Given this list of marker genes XKR6, FBLL1, SMIM18, GRID2, ANKRD44, MMP17 (NCBI Gene Id 51403), BRINP2, PPP3CB, RIPOR2, NFATC2, CACNG8, ST8SIA3, POU2F2, MAP2, C1QL4, TBC1D3, MSANTD3-TMEFF1, LHFPL4, NPY1R, FRMD4A, MEIS2, GPR155, CASZ1, RALGDS, CACNG4, INHBA-AS1, TRIM67, CREG2, PLXNA2, GATA3 (GATA binding protein 3), ZNF568, GSE1, SULT4A1, SEMA3C, SRRM4, C22orf42, ROBO1, CSMD2, KCNC1, CBLN4 (NCBI Gene Id 140689), TTLL7 (NCBI Gene Id 79739), NRN1 (NCBI Gene Id 51299), XIST, OGDHL, PCGF3, PALB2, SMPD3, RIMBP2, PPARGC1B, MAP7D2, KCNC2, SAMD5, PCDH17, NPAS4, FRMD4B, SPAST, PIGX, NALF1-IT1, VHL, FAM171B, TBC1D24, MFSD6, DACT1, CSAD, SNCA, OPRM1, PDZD7, TRIM46, RETREG1, CACNA1C, CNTNAP2, ZFHX3, GLS, CCDC39, PKIA, KIF21B, NELL1, RAB3B, UNC79, ERC1, MTSS1, ATP8A2, UBE2QL1, BAALC, RNF175, CDH4, CHL1, PSD2, RAB6B, SYT4, HS3ST1, GABRG2, CDKN2D, UBN2, CHN1, ERC2, MAP1LC3A, NALCN, GPR12, TFAP2B, CCDC144A, HCN3, AK5 (adenylate kinase 5), STXBP5, PISD, ACSL6, CFAP90, NEGR1, ELFN2, VOPP1, NUAK1, TULP4, SYBU, SORCS1, GAD2, GPM6A, AKAP1, EPHB1, ELAVL4, SNX31, SYT1 (NCBI Gene Id 6857), TMEM121B, PEG3, PFKP, OCRL, FNDC5, GPSM1, CDKL2, LRRC8C, NRXN1, KCTD8, NKAIN2, SLC4A1, GRIA1, TMEM185B, TMEM132B, SLC38A1 (NCBI Gene Id 81539), FAM131B, LRRC3B, TAC1, ATP1A3, TSPAN7, SCN3B, SNORD12, MCF2L, ASIC2, THSD7B, ATP9A, ANKRD36B, SCN7A, GOLGA8B, BCL11B, TESMIN, GNAO1, CACNG2, EPB41L1, TMEM127, DOP1A, CSMD3, NALF1, GABRA1, GRIA2, ADGRB1, SYT7, ELOVL4, CDKL5, PAK5, SCAI, MMP24, FGF14, KIFC2, MAP6, SCG2, CELF3, ATP2B2, DGKE, SPINT2, NDRG4, MAP1B, CACNA1E, MUC19, TMEM178A, CAMK2B, RAP2B, FRY, SLITRK1, SYP, DSC3, EEA1, ARPP21, INA, PLXNA4, ASXL3, ZNF264, CNTRL, PTPRT, DLG2, GABRG1, BRINP1, STAR, PCDHA7, EEF1A2, FLJ16779, CHST1, SDC3, ACSL4, SLC24A3, RUFY3, RUNX1T1, COMTD1, DOK4, SPRED3, ANK1, ANKRD13D, NLN, VSTM2A, MYCBP2, SLC37A1, KIF3B, C12orf76 (NCBI Gene Id 400073), DPP6, CCDC85A, APLP1, FAR2P2 (fatty acyl-CoA reductase 2 pseudogene 2), FRMD3, MYT1L, C11orf87, LRFN5, TBC1D32, ANKRD12, BRSK1, REV3L, UBE2J2, MAPRE3, TLN2, DICER1, REEP2, DCLK1, NDST3, PRRT2, LSAMP, LPIN1, KCNMA1, FNBP1, TMEFF2, TRHDE, PNCK, SPOCK1, ARK2C, LONRF2, SYNPR, CPEB3, NLGN1, LRRTM3, GRM7, NPAS3, KIRREL1, CMIP, EML5, SNAP91, JAG2, SSBP3, OPCML (NCBI Gene Id 4978), NRXN3, HPCAL4, PCDH19, TAL1, SCN1A, CHD5, CRMP1, PITX2, SLC32A1, PDE4D, TMEM35A, CD2, BNC2, TIGD3, ZFHX2, PNMA8B, MTCL3, DPYSL3, EID2B, CDK5R1, SNX1, SLC8A2, PRLR, NPTXR, DSCAM, RASGEF1B (RasGEF domain family member 1B), CNGB1, UNC13A, DNAJC3, MAPRE2, UBE2K, DOCK3 (dedicator of cytokinesis 3), DOCK4, SLC12A5, IKZF4, FGF9, PCDH9, SCAPER, SLCO3A1, GRIK2, TMEM129, ANK2, PKNOX1, SRRM3, CHRNA7, ENSG00000230725, ATP1B1, CCDC184, FAM182B, NRG2, SORCS3 (sortilin related VPS10 domain containing receptor 3), PXK (NCBI Gene Id 54899), AKAP7, ERAP2, GRIN3A, SRCIN1, TUBB2B, SYT13, ATP2B1, TRIM36, MAB21L1, ST3GAL2, RAB11FIP4, ZNF292, CDH8, DMTN, ASNS, GRM4, OPN5 (opsin 5), DYNC1I1, RALYL, BRINP3, SLC5A7, FMN2, PLEKHA6 (pleckstrin homology domain containing A6), SNORD116-29, XPR1, TSHZ2 (teashirt zinc finger homeobox 2), RNF125, SCN9A, KIAA1549L, NAP1L2, SEMA6D, CACNA1G, URB1, RALGPS1, MARK1, BCO2, EPHA5, TUBB3, RASA4, ZFHX4, SH3GL3, PHACTR3, WDFY4 (WDFY family member 4), GABRB3, NEIL1, ANO8, NRXN2, NSG1, PCLO, RTN1, ADAM23, KIRREL3, TGFB2-OT1, NAT1, CNTN4 (contactin 4), PRKAR2B, VGF, CMTM4, YPEL3, CCSER1, ELAVL2, EDIL3, SCN2A, BLTP3B, PAQR8, UBASH3B (ubiquitin associated and SH3 domain containing B), PGM2L1, MIR124-2HG, UCHL1, ARID4A, CACNA1A, RUNDC3B, GPRASP1, PLEKHA1, GRM8, ACVR1B, RAP1GAP2, LGI2, NCAM1, NBEA, JAKMIP1, CBLN2, TCEAL2, PSD, IDH3A, CALN1, SS18L1, TMC7, ATCAY, ANOS1, PRICKLE2, XKR4, BASP1, CCDC88A, ZNF525, STK32B, SEMA3E, PDE4DIP, TTN, RGS7BP, AKAP9, PDE11A, LRRC7, TOX2, RFK, SV2A, OLFM3, TSPYL4, JPH3, TAFA5, SHROOM2, CHERP, MYRIP, DENND3, ZNF33B, RIMS3, ROBO2, SV2B, ONECUT1, SBK1, GABRB2, ZNF573, GRK3, LRP1B, KSR2, CPEB2, CAMK2N1, SVOP, SNORD11, ZBTB38 (NCBI Gene Id 79779), RUNDC3A, TSPAN9, LRRTM4, TENM4, REEP1 (NCBI Gene Id 65055), TNRC6C, ZNF248, MCF2, TSIX, NECTIN1, SLC9A7, SCN3A, JAKMIP3, C1orf35, AKR1C1, SYNGR3, TARBP1, VAT1L, MARCHF1, SEZ6, STMN4, FGF13, GRM5 (NCBI Gene Id 2915), CADM1, SYTL2, PEX5L, ZBTB46, CELF5, SYN3, ANK3, CCDC136, ADCY2, ENPP4, KLC1, SLC9A6, KCNA3, PPP2R2C (protein phosphatase 2 regulatory subunit Bgamma), DIRAS3, PMFBP1, KCNIP4-IT1, MDGA2, RBFOX3, GUCY1A1, ZNF362, SLITRK4, CXADR, HS6ST3, BDP1, RHOU, SIRPA, PGAP1, GNPTAB, DNER, OPTN, PTPN18, C3orf62, RBMS3, CADM2, RBFOX1, ONECUT2, NTM, SEZ6L2, TMEM192, RYR2, STXBP1, THEM4, CNR1, ADORA2A-AS1 (NCBI Gene Id 649503), PBX3, ADCY1, YPEL4, PLPPR4, NKX2-2, SH3BP5, SOX14, PIANP, PIK3CD, AHDC1 (NCBI Gene Id 27245), ENC1, SERTAD4, GRIP2, SCD5, RNF112, NSG2, CD24, KCTD7, CSGALNACT1, BLCAP, FNBP1L, B4GALNT4, PPFIA4, BSN, ADGRB3, CABLES2, NOL4, GNG2 (NCBI Gene Id 54331), CACNA1B, RUNX3, OLFM1, TAFA2, DNM3, CSMD1, CDRT4, GDPD1, ZNF462, MACO1, PDPK1, PDZD4, GOLGA7B, DCX, NFASC, CBX4, ANO5, KIF3A, TERF2IP, FGF7P3, SPOCK3, KCNK6, VAV3, PPFIA2, STX3, DND1, SERPINI1, ZNF716, MAST1, NNAT, TMOD2, MPP2, RALGAPA1P1, TRIM58, TMEM196, SYN2, AATK, BACH2, NAP1L5, CA1, VASH2, MTURN, GNAL, KIF21A, CD27-AS1, EYA4, KHDRBS2, CSRNP3, YPEL2, GPR137C, KLHL1, ARFGEF3, PRKCB, FAR2, SHANK2, SCAMP1, KCNIP4, CHCHD1, CPEB4, GFOD1, SLC4A3, TAFA1, ST6GAL2, PRKACB, PAX5, SLC1A2, FBXL16, MICU3, ZNF793, CYFIP2, ELAVL3, AKR1C2, STRIP1, CHRNA4, TENM1, PAK3, PDP1, KIF5C, PCSK2, VSTM2A-OT1, ANKRD9, SV2C, GLRA2, CELF2, ADCK2, CLVS2, AMPH, GABRB1, ZNF283, BEND6, CERS6, CLVS1, L1CAM, SGTB, POLR3E, KCND2, SLC8A1, MDGA1, SCN8A, SLC17A6, MEG3, CHIC1, FHOD3, IGFBP3, SOCS7, PLCB4, CTTNBP2, PTPN5, GPR176, CNTNAP3P2, RIMS2 (regulating synaptic membrane exocytosis 2), NFIL3, GRIA4, HOOK1, CTNNA3, FRMPD4, TNK2, MPP3, ABLIM3, IRGQ, LINGO1, AJAP1, BDNF, GABBR2, DAAM1, CELF4, GP1BB, HERC2P2, CHGA, PRDM6, SLC7A14, RBFOX2, DNAJC6, MEGF6, GAP43, ZNRF3-AS1, ICA1L, RUNDC3A-AS1, TMEM74B, CEND1, ADAMTS5, PTPRK, PCDH7, SNAP25, PPARGC1A, JPH4, MIAT, CAMSAP2, RASSF5, GOLGA8A, APOL6, SOX1, SLC6A17, FAM169A, STMN2, LPCAT4, GABPB1-AS1, GK5, TMEM18, IGF1, KLHL32, TNFRSF6B, here is a description of the gene set: Human Gene Set: MANNO_MIDBRAIN_NEUROTYPES_HNBGABA from publication La Manno G, Gyllborg D, Codeluppi S, Nishimura K, Salto C, Zeisel A, Borm LE, Stott SRW, Toledo EM, Villaescusa JC, Lönnerberg P, Ryge J, Barker RA, Arenas E, Linnarsson S (PMID 27716510) species: Homo sapiens Cell types are named using anatomical and functional mnemonics prefixed by 'm' or'h' to indicate mouse and human respectively: OMTN, oculomotor and trochlear nucleus; Sert, serotonergic; NbM, medial neuroblast; NbDA, neuroblast dopaminergic; DA0-2, dopaminergic neurons; RN, red nucleus; Gaba1-2, GABAergic neurons; mNbL1-2, lateral neuroblasts; NbML1-5, mediolateral neuroblasts; NProg, neuronal progenitor; Prog, progenitor medial floorplate (FPM), lateral floorplate (FPL), midline (M), basal plate (BP); Rgl1-3, radial glia-like cells; Mgl, microglia; Endo, endothelial cells; Peric, pericytes; Epend, ependymal; OPC, oligodendrocyte precursor cells.